Given this list of marker genes KMT5A, SDHAF4, FXYD4, PIGU, SLURP1, DVL1, FASTKD2, ATP2A2, TARDBP, SPTBN2, ENOX2, PPIB, XPO5, QPCT, MLLT1, ZNF574, HUWE1, TP53INP2, C22orf39, TENM2, RPS8, TBK1, FOS, TNNI1, PADI3, GTF2B, DCT, HOXA3, FBXW8, ACAN, HOMER2, WRAP73, PFN2, IRX4, CCDC43, VAPB, USHBP1, SMO, TNMD, PEA15, UBE3A, DLK1, DHX40, RIPK4, NR2F1, S100A14, KRTAP19-3, PKIG, DKK2, KRTAP4-11, ELOVL6 (NCBI Gene Id 79071), KPNA6, PTPRZ1, PMEPA1, GALR1, NHERF2, ASB6, IMMP2L, GNMT, CA6, PRR13 (proline rich 13), THRA, TIA1, SET, GOLGA4, NCDN, LITAF, SSBP2, CCDC137, ZDHHC14, PANK1, NSMAF, HNRNPLL, ADAMTS4, PGD, SMAD4, TIMMDC1, ITGAV, TRIAP1, ARRDC4, CALR, DPYSL3, MRPL52, KDM5B (NCBI Gene Id 10765), ZNF280D, HRAS, TJP2, MSR1, LPCAT1, ECRG4, KRT23, KRTAP5-2, DUS1L, RAB4A, CPSF4, RIMOC1, KRT72, MORC3, LBP, MFAP5, RPS18, ZBED3, GINM1, ST14, CYP11A1, IGHG1, EDC4, PKD1, TOR2A, LIPA (NCBI Gene Id 3988), UAP1, PFKFB3, RNF149, PRDX1 (NCBI Gene Id 5052), RPS21, TMED10, ESD, GALNT11, KRTAP9-4, TRBC2, HAVCR2, PRNP, BPHL, MYH14, WFDC21P, ARHGEF25, KRTAP4-1, DDX3Y, SLC4A10, MBP, KRTAP19-1, NDST2 (N-deacetylase and N-sulfotransferase 2), CDKN1A, MAX, VDR, RPL31, POLR2A, ACKR1, PSMF1, EDARADD, MARCKS (myristoylated alanine rich protein kinase C substrate), CCT6A, KRTAP3-1, AGPAT5, FBP1, BAG4, RILPL2, CD36, POU1F1, BBIP1, RPGRIP1, RHBDL3, KLK1, GJB2, SLC14A1, PITX2, WDR75, KRTAP19-8, ACVR2B, MFAP3, MTA1, FBN2, PLAC1, KRTAP12-2, MAML1, EPS8L1, ME1, ILF3, COPS9, MYBL2, AGTR2, BBOX1, PPP4R3B, NDRG1, POLDIP3, TRIM2, GSTP1, CTNNAL1, KRT34, KRTAP1-3, FKBP5, CLEC10A, HSPA8 (NCBI Gene Id 3312), ATP6V0C, ACYP1, MT4, NDEL1, VIRMA, KRTAP13-2, COL11A1, GCLC, RPL37, AQR, CD248, KRTAP5-4, TSPAN3, CLCN3, TUBA4A, MGLL, RBBP8, SOX9, SLC27A4, PKP2, LDHB, NPY, CELSR2, EFTUD2, HAS3, SELENOF, SLC7A5, CPT1A, BAMBI, TOMM70, TRO, KRT81, ZMYM4, NADK, MARCHF2, EIF3E, DIAPH3, AP2A1, SON, FA2H, CPA3, UPP1, IFI16, H1-2, COX6A1, NPEPL1, CELF4, SHISA2 (NCBI Gene Id 404758), UBB, SLC1A5, LANCL1, SERPINB1, HMGCS1, COL9A3, ZSCAN26, LSR, S100B, BCR, ATP5IF1, NPM3, TMEM191C, ATP11A (ATPase phospholipid transporting 11A), FHDC1, LCE1B, ELN, KRTAP15-1, FAM162A, RPL34, DYNLT1, RCC2, CNOT4, TNNT1, TFAP2B, CXCL14, GZMB, CD163, CDH5, CDKN1C, PDCD7, CLEC4E, HADH, SRGN, CEBPB, PIP5K1A, SIX2, NFIA, CSRP3, RNF14, CAPZB, DTX3, MNDA, TGFB2, ZNF330, EGLN3, SCMH1, SLC45A3, SLC6A4, SLC22A2, NFE2L3, PLXNA2, PIP, SFRP2 (secreted frizzled related protein 2), DSTYK, ZNF521, GLO1, NFIB, SNX17, PPCDC, CTF1, TNRC6A, TNFAIP6, IL33, ADGRG1, POM121, KRT25, PDGFA, CLIP4, PTTG1IP, LAMA5, NCOA5, SCARA3, HOOK2, C5orf15 (chromosome 5 open reading frame 15), KRT31, ALDH1A3, MAN2C1, PATZ1, LCE1A, IFFO2, TMCC2, ALOX5AP, KERA, SFXN3 (sideroflexin 3), FZD7, MYO10, ZFP37, ZIC3, ALDH3A1 (NCBI Gene Id 218), KRT33B, SLC39A6, UNC5B, LTBP2, PPIH, IGDCC4, TNFRSF19, HACD4, RNASET2, TCHH, TNNT2, MTX1, TGFBI, RRN3, CSF1R, INTS6L, CIBAR1, KRT35, FNTA, IGFBP2, AP2B1, PIGQ, AGFG2, RXYLT1, ZNF410, SP110, RIMS2, SEPHS2, FLNA, NEO1, MYL4, KRT27, SLC35B1, RPL27, PROKR1, ATF1, TMEM222, ITGA4, RPS24 (NCBI Gene Id 6229), C1R, LAD1, KRTAP6-1, HLA-B, SIRPA, CHAC1, PIP4K2A, IFT46, SUPT6H (NCBI Gene Id 6830), CHST1, BASP1, ALDH1A1, CTNNBIP1, ACAD8, PIGO, NUMA1, ENPP3, SERPINB9, DCTN4, KRT83, GIT2, PRSS12, HDC, PLOD2, MARCKSL1, BICC1, PIP5K1C, KRT33A, CALCOCO2, UBE2F, SPINT1, RPS7, GRB10, SCYGR1, EGR2, MEIS2, POLR2L, RBBP4, FAAP20, UTY, MCL1, TMED9, TNNC1, SPPL2B, SMARCD2, ATF3, RHBG, CHEK2, CYP2G1P, SLC39A14, PTTG1, KRTAP19-5, KRTAP9-9, MAP4, USP19, LXN, CRYM, MAPRE2, TRH, ESRP1, GNA13, BRD3, KRT32, SNRNP27, ATP5PD, LYAR, PLXNB3, LMBR1, TYROBP, SLC44A1, ZCCHC9, H2BC5, KLK10, AHR, TLE3, SPON2, LY6G6D, ACTC1, RSAD2, S100A8, PSORS1C2, TRIB1, SCYL1 (NCBI Gene Id 57410), TFPI2, CXCL12, KRT82, FERMT3, EPAS1, MYH3, PILRA, PAX6, LAMA2, PARP3, MBD3L2, DOP1B, UCP1, NOTCH1, COL18A1, FOXO1, SMOC2, PINLYP, EFNA3, KRTAP20-1, KLHL13, FZD6, INTS9, CMA1, B2M, PRKCE, POLG, GAS1, TPSB2, RETREG3, FUBP1, ATF7IP2, GSTA2, CTTN, AARS1, GSDMA, MRPL33, RHOU, CSNK1D, BICD2, MAGOHB, RTRAF, PTPRF, CRTC3, CXXC5, RPL37A, KRTAP8-1, PTGDS, GRHL1, RPS25, H2BC13, SNTB2, KRT6B, CACFD1, RPS17, SOX11, MSX2, RPS6, LIG3, MRTFA, IDI1, CANX (calnexin), S100A3, GLIPR1L2, TMEM106C, IGFBP4, RPL21, TM6SF1, EDN3, NPY4R, IL18R1, RPL26, SRSF3, CELF1, LTBP1, NDUFS4, RPL14, ARL8B, KIF1C, TMEM109, NECTIN2, LASP1, SREK1, SIVA1, DUSP22, PDGFC, KRT86, APOE, MS4A6A, DAP, ADH1A, DNPEP, BAD, C6orf132, PLGRKT, SOX2, KRT71 (keratin 71), ECE1 (NCBI Gene Id 1889), CCN1, MTREX, SLC26A7, CLU, HSD17B11, NUDT7, IMPACT, PAM16, SERPINB4, UBC, CLNS1A, ETFRF1, CAPN6, TEX261, TXNDC12, OS9, TC2N, PSMC4, AFF2, SPESP1, CCN3, GPRC5D, EPRS1, SORT1, VN1R17P, RDH10, KRTAP4-5, PCBP2, CDK2AP1, FCGR2B, ITPR3, here is a description of the gene set: Squamous cell carcinomas (SCC) represent the most aggressive type of nonmelanoma skin cancer. Although little is known about the causal alterations of SCCs, in organ-transplanted patients the E7 and E6 oncogenes of human papillomavirus, targeting the p53- and pRb-dependent pathways, have been widely involved. Here, we report the functional consequences of the simultaneous elimination of Trp53 and retinoblastoma (Rb) genes in epidermis using Cre-loxP system. Loss of p53, but not pRb, produces spontaneous tumor development, indicating that p53 is the predominant tumor suppressor acting in mouse epidermis. Although the simultaneous inactivation of pRb and p53 does not aggravate the phenotype observed in Rb-deficient epidermis in terms of proliferation and/or differentiation, spontaneous SCC development is severely accelerated in doubly deficient mice. The tumors are aggressive and undifferentiated and display a hair follicle origin. Detailed analysis indicates that the acceleration is mediated by premature activation of the epidermal growth factor receptor/Akt pathway, resulting in increased proliferation in normal and dysplastic hair follicles and augmented tumor angiogenesis. The molecular characteristics of this model provide valuable tools to understand epidermal tumor formation and may ultimately contribute to the development of therapies for the treatment of aggressive squamous cancer. Genes down-regulated in mice with skin specific knockout of RB1 by Cre-lox. Human Gene Set: MARTINEZ_RB1_TARGETS_DN studied in species Mus musculus from publication Martínez-Cruz AB, Santos M, Lara MF, Segrelles C, Ruiz S, Moral M, Lorz C, García-Escudero R, Paramio JM (PMID 18245467)